The following is a description of a gene set: studied in species Homo sapiens A semiautonomous, self replicating organelle that occurs in varying numbers, shapes, and sizes in the cytoplasm of virtually all eukaryotic cells. It is notably the site of tissue respiration. Human Gene Set: GOCC_MITOCHONDRION, and this is the list of marker genes: RNASEL, DAP3, FDX1, C11orf65, UQCRFS1P1, TRIM34, TIMM50, CCS, TMEM135, QTRT2, CA5BP1, RFK, WDR26, SLC9A6, PRORP, TIMM22, HIGD1C, ESR2, MTHFD1 (NCBI Gene Id 4522), PC, ARL2BP, ECH1, SUGCT, ETFBKMT, ARMCX6, DHRS2, MRPS26, GTF3C4, TMEM69, ABCB8, NOC3L, DAOA, DHRS4, DLAT, UCP1, ADSS2, MTFR2, OCIAD1, ZDHHC8, FASTKD3, MICU3, COX18, LDHAL6B, TARS3, BCAT2, BCL2, TRMT1, SLC25A19 (NCBI Gene Id 60386), HS1BP3, ETFA, GPD2, CHCHD6, ATPAF2, ACSL6, BNIP1, SIRT5, LONP1, ALDH9A1, RAB11FIP5, MRPL49, DOK7, CISD3, MRPL38, PRKCA, POLR3A, MRPL34, ACSF3, STOML2 (stomatin like 2), SUPV3L1, MAP1LC3B, SLC25A15, TDH, SPATA19, IER3, CYP2D6, MRPL16, GTPBP6, RPS27A, DCPS, NLN, DDX1, TBRG4, SQOR, SLC25A2, MICU1, POLR3B, SPG7, PMPCB, CA5A, MECR, BNIP3, ULK1, MGST3, ADAM28, ARHGAP11B, TRIT1, CRY2, SH3BP5, HIGD2B, AK4, TOMM7, MRPS23, BCS1L, AGPAT5, CRLS1, GK5, FADS1, ABHD11, ACO1, RRM2B, MPV17L2, SLC25A21, AK2, NSUN2, SULT4A1, ZNF217, ATP5IF1, AGK, TRAF3IP3, TRIM39, TRMU (tRNA mitochondrial 2-thiouridylase), NAGS, COL6A1, CHCHD10, NDUFV1, MACROD1, MRPS15, UQCC1, MUTYH, GATD3, PYURF, ABHD8, ABHD6 (abhydrolase domain containing 6, acylglycerol lipase), RANBP6, ACOT9, PLPBP, MFN1, GRPEL2, SPRYD4, ISCA2 (NCBI Gene Id 122961), HSP90AA1, REEP1, LDHD, ATP2B4, PTRHD1, TMEM102, CYP27A1, XPNPEP3, SPR, CEP89, NDUFA1, ACACA (NCBI Gene Id 31), ARL10, IFT140, TATDN3, PLA2G4F, NAIF1, MPV17, THNSL1, ACBD3, BCL2L1, ATP5F1D, TMX2, BLTP1, BAG5, IDE, NME6, CLN8, MTRFR, RHOT2, PHYKPL, HSPD1, BCLAF3, TFAP4, CHCHD2, PANK2, GLYATL1, TRMT11, PARL, AMBRA1, DDX3X, FZD9, METTL8, MT-ND5, NDUFS8, ARL2 (ADP ribosylation factor like GTPase 2), COQ9, ACSS2, NDUFS2, SPMIP6, HSD17B8, TGM2, MRPL10, TUSC2, MGARP, ALDH5A1, CNR1, MIR29B1, EXD2, PLD6, SLC30A9, CSKMT, ATAD3B, TAMM41, ZMIZ2, UQCRQ, MAOA, DDAH2, ZFYVE1, YAP1, MMAA, PPP1CC, MTRES1, C3orf33, ATP2A1, CYB5R2, NOS1AP, MT-ND4L, FARS2, SGK1, FIBP, HSD3B1 (hydroxy-delta-5-steroid dehydrogenase, 3 beta- and steroid delta-isomerase 1), PINK1, FAHD2A, CYB5R3, TAFAZZIN, TRMT10C, PTGR3, SECISBP2, ALDH7A1, FPGS, CYP1A1, YRDC, RPS6KB1, MRPS33, SNAP29, MRPS16, TK2, PCCB, GSTK1, FANCG, DCAF8, ATP5PB, HSPE1, SLC25A3, TSPOAP1, EARS2, NAPG, HSPA9, HIBCH, PTPMT1, GSTZ1, GRPEL1, AASS (aminoadipate-semialdehyde synthase), HELB, TIMM23B, MIX23, DNAJC5, CDKN2A, GUF1, AADAT, TIMMDC1, RPIA, SURF1 (NCBI Gene Id 6834), TRAK2, NDUFS3, TFB1M, DUSP18, CASP4, GSK3A, SLC25A46, ANGEL1 (angel homolog 1), PITRM1, SUOX, ERCC6L2, MTERF2, MRPL3, ETNPPL, NDUFAF5, MARK2, MIGA1, FHIT, DAO, ATP5PO, CASP14, CYP2E1, HARS1, SLC25A43, MICOS13, SLC25A13, HINT3, NUDT9 (NCBI Gene Id 79013), MYOM2, KANK2 (KN motif and ankyrin repeat domains 2), VARS2, OXA1L, TIMM21, ABCB7 (ATP binding cassette subfamily B member 7), RXRA, SLC25A39, SIRT4, CAPN10, ITCH, SARDH, CRYAB, KANSL3, HARS2, LYPLAL1, TIMM17B, GPX4, SLC22A3, C19orf12, PNPT1, LIPT1, SRC, DCTPP1 (dCTP pyrophosphatase 1), MRPL14, MRPL54, SLC25A4, PDHA1, TST, GPN1, OPA3, LRRK2, MCUR1, SLC25A14, ATXN3, SNN, MALSU1, GRK2, SLC25A30, HEBP1 (NCBI Gene Id 50865), CYC1, ME1, CHDH, MRPS12, RIPK1, TTC8, NTRK1 (NCBI Gene Id 7825), LAP3, LMO7, ATP5F1B, ATCAY, FATE1, SLC25A48, MAFF, TRAK1, OXR1, MRPS24, PCK2, GCK, ANGEL2, CLYBL, SDS, HSPA5, MRPL33, TARS2, GRSF1, UQCC5, AKR1B1, MIR29C, QARS1, S1PR4, PERP, AP3B1, PEX5, NGDN, CPS1, COA7, COX6A2, IDH2, KLK6, PLN, STX17, ALAS1, HK2, VPS13A, RMND1, ZBTB6, MMAB, GSR, PPM1M, LETMD1, CAT, MRPL11, LRRC59, PPP2CA, BLTP2, GLS2, TOP3A, AGMAT, CLPX, GRHPR, NOL7, EIF2S1, COX7B2, PLA2G2A, LIAS, PIGBOS1, MFSD8, ATP7B, TMEM8B, COX8C, TIMM10B, C10orf88, PLAAT1, RBFA, MIEN1, CYP11B2 (NCBI Gene Id 1585), AK3, STARD13, UNG, UQCC3, MYG1, IQCN, SNAP23, JARID2, PDPR, COX4I1, ATP5ME, NDUFB7, COQ6, SARM1 (sterile alpha and TIR motif containing 1), HTN1, STYXL1, CDS2 (NCBI Gene Id 96708), RAB24, MTARC2, TP53, GFM1, UQCRH, RAD51, SELENOO, NDUFA2, SLC25A18, TTC5, SOX4, COQ10B, GLUL, PET117, SLC25A5, LIPT2, TWNK (twinkle mtDNA helicase), NDUFAF2, XPC, NIPSNAP1, BDH1, SLC25A42, PTRH2, GARS1, VASN, UQCC2, ECI1, TYMS, QRSL1, ADO, MTCH1, SIAH3, SIVA1, MRPS10, BTD, TERT, GLUD2, HTN3, HRC, MCCC2, MT-CO3 (mitochondrially encoded cytochrome c oxidase III), STXBP1, MTO1, NDUFB2, SYBU, GCKR, BRINP3, POU5F1B, KHDC3L, CRAT, TMEM14A, ANKRD37, USP48, DGLUCY, TSC22D1, DMAC2, P4HA1, TRAF3, LYRM7, ABHD10, KLC2, ERN1, OLFM4, CRYZ, ECHDC2 (enoyl-CoA hydratase domain containing 2), NDUFAF3, CUTA, KIFC3, SLC44A2, TPM3, AIFM1, SLC22A14, TMEM177, MPC1, RSAD1, SMCP, MYO19, ETFRF1, MAPK14, TATDN1, TMCO1, MRPL52, KANSL2, GUK1, CTPS2, MTERF1, YBEY, BAX, NOCT, UQCRFS1, MRPL37, PRELID3A, DGAT2, ALAS2, MAPK10, SLC25A53, CEND1, MIEF2, RSAD2, CEBPZOS, MRPL23, NRGN, PRELID3B, C15orf61, RNF5 (NCBI Gene Id 6048), DMAC1, TMEM65, TOP1MT, HTATIP2, SLC25A10 (solute carrier family 25 member 10), OXLD1, HMGN5, HMGCS2, MRPL42, NLRP5, MTHFD1L, MRPL43, FOXO3 (NCBI Gene Id 2309), PSMB4, PDF, PTCD2, SNPH, PRODH, XAF1, CASQ1, ARG2, ALDH6A1, FAM124B, FEM1B, GLS, MARS2, RACK1, YJEFN3, HAT1, SLC25A24, ADCK1, KMO, MT-ND3, PUS10, SLC29A3, NDUFB8, TFB2M, NT5DC3, SULT1C2, CALM3, HOGA1, PSEN1, AFG1L, SUCLG2, CHCHD3 (coiled-coil-helix-coiled-coil-helix domain containing 3), KYAT1, CCM2, CRYM, ECI2 (enoyl-CoA delta isomerase 2), PRELID1, MFHAS1 (NCBI Gene Id 9258), EXOG, AKR7A2, GTPBP8, USP15, CKMT2, MTX2, SUCLG1, RNASET2, ECHS1, ACSM3, LRRC10, RRM1, MTCH2, CKMT1A, FOXK2, BMF, MRPL55, COX7A2P2, CARD19, TIMM44, SMIM12, GPAT2, TSPO2, CERT1, MAPK1, SHC1, CPT2, CISD1, STAP1, MCU, STARD3, COX7C, CCNB1, FIS1, NDUFS7 (NADH:ubiquinone oxidoreductase core subunit S7), UBC, FLVCR1, TOMM40, SSBP1, LRPPRC, NDUFA9, MRPS7, MYOC (myocilin), TSFM, NOA1, MRPL51, UROS, ACSM2B, PLEKHN1, TRIM24, LACTB2, FKBP4, COA6, LYRM4, CANX, ENOSF1, PDPN, MIURF, MPST, ABCD1 (ATP binding cassette subfamily D member 1), AURKAIP1, SCCPDH, RHOD, ANXA6, TOMM40L, CLIC1 (NCBI Gene Id 257617), FKBP8, TIMM29, MT-CYB (NCBI Gene Id 4519), MRPS31, PRNP, KRAS, MT-ATP6, ZNF205, MFF, AKR1B10, CYP1B1, MRPS28, DDX21, IFI27L2, MMADHC, CFL1, C10orf67, CISD2, ATP5PF, PTRH1 (NCBI Gene Id 138428), ENY2, AGPS, RHBDD1, PIN4, SMURF1 (SMAD specific E3 ubiquitin protein ligase 1), CHPF, FAM72A, HIGD1A (NCBI Gene Id 25994), MRPL30, MRPL19, GLYCTK, UCP2, PPP2R1A, SLC25A22, ALKBH1, GLYATL3, VDAC1, NDUFV2, ETFB, MMP3, CYRIB, SACS (sacsin molecular chaperone), NME3, SFXN1, PI4KB, ADCK2, SLC25A1, NARS2, GATM, ADHFE1, TOMM5, EYA2, MICU2, SELENON, RMDN2, SYNE2, HINT2, TMEM70, MTX1, MRPS18B, SFXN4, URI1, GLYATL1B, APOO, REXO2, POLR1G, ADAP2, PDP1, BECN1, DHRS4L2, NT5C, COX10, AMACR, SOD1, YWHAH, ENDOG, UQCRC1, PRICKLE3 (prickle planar cell polarity protein 3), ALKBH3, IRF3, FAM162A, PPP3CC, EOLA1, MAPK12, ACADL, MRPS30, ATP5MF, NDUFAF7, NIT1, ADH5, PDE2A, MT-CO1, ROMO1, TRIAP1, FDXR, FASTK, SLC35F6, PGAM5, PHB2, AQP8, PGK1, AKAP1, HDHD3, HCCS, METTL9, SLC25A37, MRPS14 (mitochondrial ribosomal protein S14), GPAM, STAT3, NDUFB3, MRPL22, RALA, COX5A, BSG, SLC25A41, UBA1, G0S2, SESN2, RAC2, ANTKMT, PLAAT3, HIVEP1, DMGDH, METAP1D, PDE12, SMIM8, VDAC2, SLC44A1, RACGAP1, PECR, MLLT11, AFG2A, TOMM34 (translocase of outer mitochondrial membrane 34), MT-ND1, TMEM126B, TMEM186, PYCARD, BOLA3, UBA52, MT-ND6, NME4, PABPC5, ATP23, NEU4, CASP8, ABCG2, LDHA (NCBI Gene Id 3939), PFDN2, CMPK2, PPDPF, PCBD2, TIMM13, ATG13, SLC22A4, HKDC1, VDAC3, AMMECR1, CWC15, PMAIP1, NDUFS6, ECHDC3, OXCT2, OXCT1, PGR, HTD2, MRPL4, ARAF, PAGE4, CLPB (ClpB family mitochondrial disaggregase), ILF3, NDUFC2, SPHK2, KYAT3, MTUS1, STAR (NCBI Gene Id 6770), GABARAPL1, PSMA6, S100A1 (NCBI Gene Id 6271), MCEE, COX7A2, UQCR10, RAB40AL, MOCS1, LETM1, RAB38, MRPL45, SLC8A3, MIR17, WDR81, TUSC3, COX14, ABL1, SLC25A28, ATP5MK, XRCC3, ACSM5, DNA2, TMEM242, PDHX, FOXO1, POLR2A, NAXD, CIAPIN1, MLXIP, TEFM, SP140, CDK1, OGDH, ADCK5, USP30, CAVIN1, IFI6, PKM, FYN, OGG1, GLOD4, SMAD5, AIM2, ACSF2, PUS1, GDF5-AS1 (NCBI Gene Id 554250), USP35, AMBP, BAD, RAD51C, HIP1R, SCP2, MPC1L, ATP5MGL, TDRD10, PDK2, FEM1A, GSK3B, L2HGDH, AARS2, SLC25A38, TIMM17A, MRPS17, MRRF, AIFM2, BPNT1, MRPS25, DHFR, SLC30A2, ACAD9 (NCBI Gene Id 96656), UBE3B, PDSS2, MRPS21, FAM185A, TMEM11, COA8, ACAA2, COQ3, POLRMT, MT-ND4, METTL17, POU5F1, ADPRS, ACOT7, RNASEH1, SMIM20, ATP5MC2, MTHFD2, CLU, BLOC1S2, DHFR2, MTCO2P12, MTFP1, MTFR1, TIMM10, GSDMD, ACSBG2, FBXO7, ACSL1, PARK7, UQCC6, MRPL40, FLVCR2, HSPA1A, HAUS3, SYNJ2BP, DTYMK, HK1, VAMP1, ABAT, NFS1, CIBAR1, MDH2, WARS2 (NCBI Gene Id 10352), CPT1A, QTRT1, PLA2G6, NDUFA7, YME1L1, TIMM9, LIG3, DUSP21, C14orf119, MTG1, PGS1, MRPL24, HSPA1B, RAP1GDS1, THOP1, RPUSD4, IFIH1, OSGEPL1, METTL13, TMLHE, NDUFC2-KCTD14, MMP2, PISD, NDUFB4, SLC9A1, SLC25A16, COX7B, GPS2, TXNRD2, DLST, PDHB, DNAJA1, AGXT2, GSTP1, COX6A1, NSUN4, PFDN4, MIEF1, PIWIL4, MRPL50, RMDN3, PPP2R2B, ALDH1B1, DDX28, NDUFV3, SORD, BBC3, SLC25A27, CKB, GPER1, MRPS5, CMC2, ACSL3, PEMT, MRPL53, MCCD1, MYCBP, TRIM32, MRPS35 (mitochondrial ribosomal protein S35), GPAA1, RNF185, PRDX5, C15orf62, HSPB6, SLC25A45, NFU1, CASP9, CHCHD7, METTL15, RPS6KA6, ACOD1, TMEM141, ARMC12, SLC25A44, GFM2, UQCRHL, SLC25A35, SOD2, GCAT, MAVS, COX15, EOLA2, HIF3A, RDH13, ARMCX1, KIFBP, JTB, BRD8, ACOT11, FAHD1, NDUFS4, MRPL57, CREB3L4, ACSM2A, GJA1, SLC25A31 (solute carrier family 25 member 31), IRGM, PPM1K, NIPSNAP3B, ATPAF1, DNAJC30, HPDL, THEM5, MAPK9, CYP2U1, NDUFA3, TOMM6, TCHP, DNAJC19, AZIN2, UQCR11, TXNRD3, MIGA2, COX6B2, DEPP1, LYRM9, UFL1, MSRA, COQ4, CFAP410, CYB5B, COX16, PPP1R15A, HAGH, NAT8L, KARS1, FH, OXNAD1, DTD1, FECH, DCXR, TRMT10B, MTERF4, SDHB, HSP90B2P, FUNDC1, NDUFA10, NCBP2AS2, DMAC2L, SLC25A51, NDUFA4L2, DEGS1, ALMS1, KLC3, CAMK2A, C15orf40, CHCHD5, CREB1, BRAF, IFI27L1, ATP5F1A, GLYAT, STMP1, SMIM26, NTHL1, TFAP2C, MPC2, MARCHF5, MFN2, MRPL46, BCL2A1, RNF144B, MRPS18A, SPARC, HSD17B10, SH3GLB1, STK11, ATG4D, PTS, MOAP1, ACSS1 (acyl-CoA synthetase short chain family member 1), PLEC, SLC25A11, AMT, APP, MRPS6, TEX10, SLC25A12, IMMT, NDUFAF1, NDUFAB1, BOLA1, NDUFS5, ETHE1, TMX1, COA4 (NCBI Gene Id 51287), NMNAT3, ACSL4 (acyl-CoA synthetase long chain family member 4), KCNQ3, PAK5, ARGLU1, IDH3G, ACSS3, MT-ND2, BOK, HSDL2, ATP5MG, ADAR, DNLZ, GK, YARS2, EFHD1, CLIC5, NADK2, NDUFB10, C2orf69, ATG9A, MTIF3, PRODH2 (NCBI Gene Id 58510), MGST1, HSCB, RAB29, ABCB6, RAB5IF (RAB5 interacting factor), CASP8AP2, NDUFC1, POLQ, CLPP, BAG3, SLC9B2, FXN, ALDH4A1, GLRX2, CYP27C1, PTCD3, MTG2, ARMS2, DHODH, FOXO3B, AKAP10, ATP5MC3, SDHA, SARS2, AGTPBP1, BLOC1S1, LYN, DDIT4, TCAIM, POLG2, PRDX3, SPNS1, FAM83A, YWHAG, RAB7A, NGB, NUDT2, CPT1B, ALPL, ERBB4, LYRM2, PAM16, NR3C1, ZNFX1, COX8A, TIMM8A, ATP5F1E, GLDC, NLRX1, NENF, SEPTIN4, MRPL35, GCDH, DNM1L, DUS2, KANSL1, NT5C3A, PRXL2B, APOOL, TSPO, OPA1, LPIN1, RGS2, CYB5R1, CYP11A1, HADH, ATAD1 (ATPase family AAA domain containing 1), TXNRD1, HRK, NTPCR, BCL2L13, C15orf48, PDP2, SLMAP, SAMM50, BCKDHA, APEX2, TACO1, QDPR, MAPK8IP1, DUSP11, NUDT1, TDRKH, PPA2, STPG1, PYROXD2, SFXN3, MTPAP, MSRB3, LDHB, BNIP3L, THEM4, RPS3, CREBZF, NDUFB6, MRPL36, COQ10A, DUT, LACTB, IFI27, UCP3, GK2, MAOB, ALDH2, MRPL20, NSUN3, GLRX5, LCA5, ATF2, NDUFA8, FAM210A, VPS54, POLG, SPIRE1, IDH3A, TMEM223, NDUFAF6, MRPL2, SPATA20, MOBP, PDK1, FBXL4, VPS13D, DBT, MTNAP1, PRKN, C8orf82, COX11, GDAP1, DCK, PPM1H, CPNE3, TRMT5, FAM110B, FAM210B, ABHD18, TIMM8B, SPATA18, PREPL, RCC1L, ARMC1, HDHD5, MTRF1L, NR2F6, RARS2, GPT2, THG1L, RAB11FIP3, MPV17L, STARD7, BLID, C1orf43, SCO2, LYPLA1, FGR, PNPLA8, MAP2K1, CLUH, GOT2, ATP5MC1, TAX1BP1, HAP1, DECR1, IFIT3, PPP3R2, DGUOK, NDUFB9, POLR2B, VRK2, SLC25A47, ACAD8, FN3K, SLC25A25 (solute carrier family 25 member 25), UQCRC2, PRELID2, KAT8, MTLN, COQ5, TRMT2B, TUFM, OVCA2, LGALS3, TIGAR, MRPL9, FTMT, ABHD5, SLC27A3, TANGO2 (transport and golgi organization 2 homolog), GABBR1, PLSCR3, CCDC51, CFAP91, NUDT8, SQSTM1, SOX10, CCDC90B, GRAMD4, PALLD (NCBI Gene Id 51653), LYRM1, MRPL48, MTOR, ARMC10, TRABD (TraB domain containing), NDUFAF8, FLAD1, SETD9, SDHAF3, MXD1, ERAL1, MCUB, PDK4, ABHD4, GIMAP8, NDUFA5, C1QBP (complement C1q binding protein), ACADSB, LDHC, HMOX1, TMEM160, ATG4B, CCDC127, MCL1, TIMM23, NUDT6, CKMT1B, TOMM20, CBR4, DNAJC11, MRPL1, CYP11B1, BCL2L2, ARHGAP26, IDH3B, MTHFS, TRIM14, ARID4B, MTFR1L, PYCR1, OAT, SHMT2, MCAT, SECISBP2L, TRUB1, ALDH1L1, CLIC4, PLIN5, MLYCD, SDHC, COMTD1, PLGRKT, PLA2G4B, BCKDK, NDUFB11, IVD, MRPL44, MRPS2, SLC25A23, MRPL39, PTGES2, CCN6, MT3, DIP2A, SPATA33, GDAP1L1, PNPO, SIRT3, PLA2G4C, ZNF703, BCL2L10, ACOT2, SMDT1, GCLC (NCBI Gene Id 2729), ISCU, NDUFA4, PTAR1, YWHAE, PARP9, MRPS9, FAM136A, COX20, BID, PET100, HSDL1, CAPN1, IMMP2L, NFKB1, PGRMC1, ABCE1, TMEM14B, CA5B, MT-CO2 (mitochondrially encoded cytochrome c oxidase II), MTX3, CYB5A, FDPS, NRP1, DNMT1, FAM222B, FEN1, DHX36 (NCBI Gene Id 96337), AUH, PLA2G4A, VPS13C, PRKACA, CMC1, CS, PPM1J, NUBPL, CYCS, HEBP2, SFXN2, D2HGDH, RAF1, PACS2, MRM1, TOMM70 (translocase of outer mitochondrial membrane 70), FMC1, RTL10, TARDBP, HYOU1, KIF28P, SLC25A6, TRAP1, OGDHL, MRPL41, KCNK16, SMIM10L1, GIT1, HIGD1B, ASAH2, SLC25A26, AFG3L2, NDUFB5, TMEM126A, SLC25A33 (solute carrier family 25 member 33), CMC4, YKT6, ISOC2, ALKBH7, PUSL1, NDUFA13, FAHD2B, TOMM22, MRPL15, SCO1, ME3, NRDC, SLIRP, OMA1, ATAD3A, MRM2, TMEM14C, MT-ATP8, ACSM4 (acyl-CoA synthetase medium chain family member 4), IARS2, MSTO1, ADCY10, KIF23, MCCC1, GPX1, CRY1, OGT, NOL6, CAPRIN2, MMUT (methylmalonyl-CoA mutase), COX6B1, ACOT1, DLD, HSD3B2, SDR39U1 (short chain dehydrogenase/reductase family 39U member 1), MRM3, TXN2 (NCBI Gene Id 25828), PYCR2, DARS2, NIT2, MICOS10, CPT1C, TMEM14EP, ACYP2, TRAFD1, CDC25C, SUCLA2, CPOX, CHCHD1, IKBKE, GATB, TPPP, CARS2, ACAD11, HADHA (NCBI Gene Id 3030), BCAT1, COX5B, DELE1, PPP6C, NOL3, MLDHR, UQCRB, TFAM, PDSS1, SLC11A2, COASY, FKBP10 (NCBI Gene Id 60681), WWOX, CYP24A1, ASB9, DISC1, DCAKD, HIBADH, TP53AIP1, COX17, TDRP, NOX4, MRPS22, MUL1, RHOT1, PRKCD, PEX11B, PNKD, ABCG1, PARS2, SLC39A9, NDUFA11, OAS1, TICAM1, ETFDH, NDUFA6, LETM2, PPOX, RIDA, ALDH1L2, SIRT1, HK3, COA3 (NCBI Gene Id 28958), ECSIT, ELK1, WASF1, FDX2, COX19, EPHA4, NLRP3, ANK2, CHCHD4, SMIM30, HMGCL (NCBI Gene Id 3155), ABCD3, VHL, PMPCA, SIRT2, KIAA1191, PIF1, MTHFD2L, MAPK3, PRKCE, ATAD3C, KYNU, CXorf38, NACC2, C1orf53, NNT, KIF1B, NAXE, LDHAL6A, PPIF, METTL4, ACAT1, TRUB2, ACAD10, ACSL5, AKT1, HUWE1, SLC25A20, PI4K2A, DIABLO, STUB1, NCBP1, OXSM, CIDEA, ACO2 (aconitase 2), MIR29A, SPART, NEURL4, COQ8B (NCBI Gene Id 79934), MRPL58, TMEM143, BRI3BP, GTPBP3, HSP90AB1, KGD4, UBIAD1, CDK5RAP1, BCL2L11, SNCA, LGALS12, SERAC1, COQ8A, SFXN5, SLC41A3, RPL7L1, SDE2, MIPEP, NIPSNAP2, NOS1, HSH2D, PARG, MGME1, PARP1, FASTKD1, NDFIP2, ELK3, BBOX1, FOXRED1, TMEM71, IBA57, MRPS34, MPG, NDUFAF4, ISCA1, HYKK, NR4A1, MRPL47 (mitochondrial ribosomal protein L47), BDH2, PSMB6, NDUFB1, SLC25A36, SLC30A7, PCK1, PRIMPOL (primase and DNA directed polymerase), PTPN11, OCIAD2, TMEM14DP, IMMP1L, ABCB10, NUDT13, MYL10, COQ7, NT5M, COX6C (NCBI Gene Id 1345), NBR1, DHX30, GTPBP10, GATC, TNRC18, RPUSD3, HEMK1, MTFMT, DNAJC15, NT5DC2, COA5, AGPAT4 (1-acylglycerol-3-phosphate O-acyltransferase 4), SLC8B1, KCNK9, MRPL13, COX4I2, VWA8, MAPKAP1, SDHAF2, DNAJA3, NIF3L1, STING1, SPHKAP, COQ2, SLC25A29, FUNDC2 (FUN14 domain containing 2), PDZD8, CKAP4, SLC25A40, MSRB2, MTERF3, MRPL28, ACACB, SLC25A52, MRPL12, GCSH, HSD17B7 (hydroxysteroid 17-beta dehydrogenase 7), MRPS27, HLCS, HCLS1, HEATR1, IDH1, ME2, LRRK1, HADHB, MRPL17, SHMT1, MTIF2, PCCA, DHFRP1, GADD45GIP1, RTN4IP1, GFER, GLYATL2, MTARC1, ARMCX3, CCR7 (C-C motif chemokine receptor 7), TRIM27, RALBP1, MRPL18, NGRN, PPP3CA, VAT1, RAB32, PHB1, TRMT61B, PNPLA4, PPTC7, AARS1, AIFM3, PTCD1, TMEM256, ACP6, ATP5F1C, ACOT13, CDK18, VPS35, POLDIP2, TRIM31, ATP5F1EP2, BCKDHB, BIK, NDUFS1, TRNT1, BPHL, ATP5PD, MRS2, ATP5MJ, DHX32, KATNAL1, HAX1, APEX1, MAPT, ACADVL, ARMCX2, PDHA2, MISFA (NCBI Gene Id 100506540), HIGD2A, MRPS11, NIPSNAP3A, SAMD9L, PCF11, MRPS18C, OTC (ornithine transcarbamylase), COX7A1, SDHAF1, AKR1B15, ACADS, MAP2K2, ENSG00000293600, NDUFA12, BCO2, FASTKD2, GLUD1, PTPN1, NUDT19, MRPL27, COA1, BAK1, COX7A2L, POLR1B, KIF5B, MRPL32, ATPSCKMT, C22orf39, ALDH18A1, ELAC2, LARS2, CYP27B1, DMPK, PDK3, OPRK1, GOLPH3, CALR, TOMM20L, UQCC4 (ubiquinol-cytochrome c reductase complex assembly factor 4), PINX1, CABS1, SLC25A34, LIPF, MTRF1, POLR1A, UBB, DYNLL1, ACSM6, SLIT3, MACC1, FASTKD5, TMIGD1, SDHAF4, ABCC9, HTRA2, TTC19, STOM, DHTKD1, MBLAC2, SLC25A32, ACADM, RMDN1, ACSM1, MRPL21, ASS1, SDHD, ARL4C, GHITM, P2RX7 (NCBI Gene Id 5027), TARS1, NOD2, MAIP1, CCAR2